The following is a description of a gene set: species: Homo sapiens Genes up-regulated in comparison of naive B cells versus plasma cells. from publication Good KL, Avery DT, Tangye SG (PMID 19124732) Enhanced secondary Ab responses are a vital component of adaptive immunity, yet little is understood about the intrinsic and extrinsic regulators of naive and memory B cells that results in differences in their responses to Ag. Microarray analysis, together with surface and intracellular phenotyping, revealed that memory B cells have increased expression of members of the TNF receptor, SLAM, B7 and Bcl2 families, as well as the TLR-related molecule CD180 (RP105). Accordingly, memory B cells exhibited enhanced survival, proliferation and Ig secretion, as well as entered division more rapidly than naïve B cells in response to both T-dependent and T-independent stimuli. Furthermore, both IgM and isotype switched memory B cells, but not naïve B cells, co-stimulated CD4+ T cells in vitro through a mechanism dependent on their constitutive expression of CD80 and CD86. This study demonstrates that upregulation of genes involved in activation, co-stimulation and survival provides memory B cells with a unique ability to produce enhanced immune responses and contributes to the maintenance of the memory B cell pool. Human Gene Set: GSE13411_NAIVE_BCELL_VS_PLASMA_CELL_UP, and this is the list of marker genes: QRSL1, AP1B1, RPL10, PTPN18, HOXA5, SETX, PIKFYVE, ZCCHC2, DIXDC1, VPS8, HSF2, COX16, LY86, MX2, ZNF665, SOCS1, NEUROD1, ZNF273, GIT2, VPS11, SERPINB1, PAK2, ATAD2B, CAST, NUDT3, IL4R, PFDN5, TRBC1, PER2, PLAG1, KIF21B, DEK, PIK3CD, EML4, CD83, DAAM1 (dishevelled associated activator of morphogenesis 1), DENND2D, GPM6A, TRIM13, RNF220, CRYBG1, IL27RA, GON4L, TUG1, SH2B3, RNF141, PPP1R16B, ARHGEF6, BHLHE40, NPIPA1, RBM8A, RBCK1, TRMT2B, HHEX, NFKB1, JADE1, PDZD8, NACA4P, TARBP1 (TAR (HIV-1) RNA binding protein 1), SPRY1 (NCBI Gene Id 91129), DENND5A, FBXL14, PTBP2, REL, ZFP37, WDR74, SIDT1, FRAT1, ZMYM4, GRK5, DAZL, DCLRE1C, WWC3, DDX52, CD1C, CNTRL, AQR, FGF9, GSK3B, SLC15A3, DGKA, HLA-DPB1, DGKD, GAREM1, CD19, DCK, CYB5R3, PTPRK, CORO1A (NCBI Gene Id 11151), USP24, RIOK3, PHC1, NT5E, LAT2, MPPE1, SLC2A3, NOTCH2, NUP210, ANKRD1, AUTS2, GCC1, MGA, KIF16B (NCBI Gene Id 79757), ABHD17A, ABR, APP, UPF1, PRR5L, ZNF672, ATP6V0E2, ALDOC, TRIM33, STK17A, AKTIP, EVL, MTHFSD, SSBP2, RAB11FIP1, RNF187, ARMCX2, KDM6A, ZSCAN18, ARHGAP25 (Rho GTPase activating protein 25), ZMAT3, PPDPF, PMS2P2, BCL2A1, MACF1, SCAF4, TM6SF1 (NCBI Gene Id 53346), BCL6, DALRD3, IL11RA, CHD3, ACACA, RASSF2, ARHGEF7, OFD1 (OFD1 centriole and centriolar satellite protein), PRAMEF10, ZNF318, RUBCNL, DENND3, CWC25, SP100, BACH2, IMPACT, REPIN1 (replication initiator 1), LCK, CD74, RUNX3 (NCBI Gene Id 864), SAV1, KLF4, CD200, SSH1, P2RX5, PLEKHF2, INPP5B, SART1, ISL1, PEX7, ZNF345, JAM3, RBM38, ADGRE5, STK19, SNN, PSME3IP1, SNX29P2, FYN, NFATC3, LAIR1, OSER1, WNT6, RPS10P5, BIN1, TRDMT1, ADAM28, CLK2, BCL11A, DNPH1, PKD1P1, ALOX5, HLA-DRB4, RPL31, TRAF3IP2, RNASET2, IL24, CBLB, TP53BP2, UBXN1 (NCBI Gene Id 92151), CAPG, LINC00667, JADE2, GALNT10, GPRASP1, JADE3